The following is a description of a gene set: A process that is carried out at the cellular level which results in the assembly, arrangement of constituent parts, or disassembly of a lysosomal membrane. A lysosomal membrane is the lipid bilayer surrounding the lysosome and separating its contents from the cell cytoplasm. studied in species Homo sapiens Human Gene Set: GOBP_LYSOSOMAL_MEMBRANE_ORGANIZATION, and this is the list of marker genes: CHMP4A, RUFY4, CHMP1A, CHMP3, CHMP5, CHMP6, ATP10B, CHMP2B, CHMP2A, CHMP7, CHMP4B, LAPTM4B, LAPTM5, CHMP1B, CHMP4C